Given this list of marker genes RAC2, IL6ST, MYD88, ITGB2, SMARCD2, here is a description of the gene set: Separation of the umbilical cord occurs at an abnormally late timepoint. Delayed umbilical cord separation species: Homo sapiens Human Gene Set: HP_DELAYED_UMBILICAL_CORD_SEPARATION